Given this list of marker genes SLC33A1, KPNA3, WASHC5, UBAP1, RTN2, CPT1C, here is a description of the gene set: An anomaly identified by motor evoked potentials (MEPs) in the leg. Human Gene Set: HP_ABNORMAL_LOWER_LIMB_MOTOR_EVOKED_POTENTIALS Abnormal lower-limb motor evoked potentials species: Homo sapiens